The following is a description of a gene set: Early prostate development genes (up-regulated at 6 h dihydrotestosterone) which are also up-regulated in normal epithelium vs high grade prostatic intraepithelial neoplasia (PIN). Cancer cells differentiate along specific lineages that largely determine their clinical and biologic behavior. Distinct cancer phenotypes from different cells and organs likely result from unique gene expression repertoires established in the embryo and maintained after malignant transformation. We used comprehensive gene expression analysis to examine this concept in the prostate, an organ with a tractable developmental program and a high propensity for cancer. We focused on gene expression in the murine prostate rudiment at three time points during the first 48 h of exposure to androgen, which initiates proliferation and invasion of prostate epithelial buds into surrounding urogenital sinus mesenchyme. Here, we show that androgen exposure regulates genes previously implicated in prostate carcinogenesis comprising pathways for the phosphatase and tensin homolog (PTEN), fibroblast growth factor (FGF)/mitogen-activated protein kinase (MAPK), and Wnt signaling along with cellular programs regulating such 'hallmarks' of cancer as angiogenesis, apoptosis, migration and proliferation. We found statistically significant evidence for novel androgen-induced gene regulation events that establish and/or maintain prostate cell fate. These include modulation of gene expression through microRNAs, expression of specific transcription factors, and regulation of their predicted targets. By querying public gene expression databases from other tissues, we found that rather than generally characterizing androgen exposure or epithelial budding, the early prostate development program more closely resembles the program for human prostate cancer. Most importantly, early androgen-regulated genes and functional themes associated with prostate development were highly enriched in contrasts between increasingly lethal forms of prostate cancer, confirming a 'reactivation' of embryonic pathways for proliferation and invasion in prostate cancer progression. Among the genes with the most significant links to the development and cancer, we highlight coordinate induction of the transcription factor Sox9 and suppression of the proapoptotic phospholipid-binding protein Annexin A1 that link early prostate development to early prostate carcinogenesis. These results credential early prostate development as a reliable and valid model system for the investigation of genes and pathways that drive prostate cancer. studied in species Mus musculus from publication Schaeffer EM, Marchionni L, Huang Z, Simons B, Blackman A, Yu W, Parmigiani G, Berman DM (PMID 18794802) Human Gene Set: SCHAEFFER_PROSTATE_DEVELOPMENT_AND_CANCER_BOX1_UP, and this is the list of marker genes: CHD4, SMARCA2, PRPF40A, EIF2AK2, SIN3B, NFIX, HADH, ZNF664, BSDC1, PSMC6, TLE1, KDM3B, PTGR1, HMGCR